The following is a description of a gene set: The chemical reactions and pathways resulting in the breakdown of heparan sulfate proteoglycans, which consist of a core protein linked to a heparan sulfate glycosaminoglycan. The heparan sulfate chain is composed of the repeating disaccharide unit beta-(1,4)-N-acetyl-D-glucosamine-alpha-(1,4)-hexuronic acid, the former being either sulfated or deacetylated on its amino group as well as sulfated on one of its hydroxyl groups, and the latter being a mixture of sulfated and nonsulfated D-glucuronic and L-iduronic acids. Human Gene Set: GOBP_HEPARAN_SULFATE_PROTEOGLYCAN_CATABOLIC_PROCESS species: Homo sapiens, and this is the list of marker genes: IDUA, SGSH, GPC1, HPSE, NAGLU, IDS, GNS, GUSB, GLB1, HGSNAT